The following is a description of a gene set: species: Mus musculus Catalysis of the transfer of an acyl group to an oxygen atom on the acylglycerol molecule. Mouse Gene Set: GOMF_ACYLGLYCEROL_O_ACYLTRANSFERASE_ACTIVITY, and this is the list of marker genes: Dgat2l6 (diacylglycerol O-acyltransferase 2-like 6), Lpcat1, Lclat1, Awat2, Dgat1, Agpat5, Mogat2, Agpat4, Lpgat1, Lpcat2, Gpat3, Agpat2, Pnpla3, Pnpla2, Pla2g15, Dgat2, Agpat3, Gpat2, Mogat1, Abhd5, Agpat1